Given this list of marker genes Bloc1s2, Rab22a, Rab5a, Ap2m1 (adaptor-related protein complex 2, mu 1 subunit), Rab3b, Borcs6, Chmp3, Rin3, Borcs5, Kxd1, Borcs8, Dnm1, Borcs7, Washc5, Pclo, Snapin, Bloc1s1, Picalm, Als2, here is a description of the gene set: studied in species Mus musculus Mouse Gene Set: GOBP_REGULATION_OF_VESICLE_SIZE Any process that modulates the size of a vesicle.